The following is a description of a gene set: electronically inferred by orthology from the curated human pathway studied in species Mus musculus Reactome Pathway: Signaling by NODAL This event has been computationally inferred from an event that has been demonstrated in another species.<p>The inference is based on the homology mapping from PANTHER. Briefly, reactions for which all involved PhysicalEntities (in input, output and catalyst) have a mapped orthologue/paralogue (for complexes at least 75% of components must have a mapping) are inferred to the other species. part of: Developmental Biology, and this is the list of marker genes: Mapk3, Smad3